Given this list of marker genes Nr2f2, Il6ra, Cnot3, Pank3, Snca, Samhd1, Krt85, Xist, Il1r2, Mbp, Arhgap9, Rbfox2, H2-D1, Zbtb20, Aif1l, Hal, Ddx6, Cd8a, Kif5b, Gdpd3, Gpc3, Malat1, Nemp2, Resf1, Tmem100, Kcnk1, Cbx5, Fgf23, Clec3b, Mlf1, Jak1, Zfp689, Rbm5, Eif3l, Dpp4, Cpa5, here is a description of the gene set: Mouse Gene Set: HOWLIN_CITED1_TARGETS_1_UP from publication Howlin J, McBryan J, Napoletano S, Lambe T, McArdle E, Shioda T, Martin F (PMID 16278680) Genes up-regulated in mammary glands from the CITED1 knockout mice: homozygotic vs. heterozygotic animals. Expression microarray analysis identified CITED1 among a group of genes specifically upregulated in the pubertal mouse mammary gland. At puberty, CITED1 localizes to the luminal epithelial cell population of the mammary ducts and the body cells of the terminal end buds. Generation of CITED1 gene knockout mice showed that homozygous null mutants exhibit retarded mammary ductal growth at puberty and, in addition, dilated ductal structures with a lack of spatial restriction of the subtending branches. Analysis of CITED1 homozygous null and heterozygous null mammary gland gene expression using microarrays suggested that the mammary-specific phenotype seen in the homozygous null females is due to a disturbance in the transcription of a number of key mediators of pubertal ductal morphogenesis. These include estrogen and TGFbeta responsive genes, such as the EGFR/ErbB2 ligand, amphiregulin, whose transcription we suggest is directly or indirectly regulated by CITED1. species: Mus musculus